The following is a description of a gene set: studied in species Homo sapiens Human Gene Set: SCIAN_INVERSED_TARGETS_OF_TP53_AND_TP73_UP Genes that were inversely correlated in H1299 cells (lung cancer): up-regulated by P53 and down-regulated by P73. from publication Scian MJ, Carchman EH, Mohanraj L, Stagliano KE, Anderson MA, Deb D, Crane BM, Kiyono T, Windle B, Deb SP, Deb S (PMID 17982488) When normal cells come under stress, the wild-type (WT) p53 level increases resulting in the regulation of gene expression responsible for growth arrest or apoptosis. Here we show that elevated levels of WT p53 or its homologue, p73, inhibit expression of a number of cell cycle regulatory and growth promoting genes. Our analysis also identified a group of genes whose expression is differentially regulated by WT p53 and p73. We have infected p53-null H1299 human lung carcinoma cells with recombinant adenoviruses expressing WT p53, p73 or beta-galactosidase, and have undertaken microarray hybridization analyses to identify genes whose expression profile is altered by p53 or p73. Quantitative real-time PCR verified the repression of E2F-5, centromere protein A and E, minichromosome maintenance proteins (MCM)-2, -3, -5, -6 and -7 and human CDC25B after p53 expression. 5-Fluorouracil treatment of colon carcinoma HCT116 cells expressing WT p53 results in a reduction of the cyclin B2 protein level suggesting that DNA damage may indeed cause repression of these genes. Transient transcriptional assays verified that WT p53 repressed promoters of a number of these genes. Interestingly, a gain-of-function p53 mutant instead upregulated a number of these promoters in transient transfection. Using promoter deletion mutants of MCM-7 we have found that WT p53-mediated repression needs a minimal promoter that contains a single E2F site and surrounding sequences. However, a single E2F site cannot be significantly repressed by WT p53. Many of the genes identified are also repressed by p21. Thus, our work shows that WT p53 and p73 repress a number of growth-related genes and that in many instances this repression may be through the induction of p21., and this is the list of marker genes: MMP17, RHCE, FTL, ASB4, GPR3, TP53, PCNA, PEPD, H3C11, SLC28A2, ST3GAL4